Given this list of marker genes IGKV7-3, SLC14A2, KCNA6, NDUFA1, TMEM106A, SLC2A4, POLR1HASP, ERV3-1, HMGA2, NRF1, SMARCD1, LYST, COL14A1, MPP2, FANCC, ERCC4 (NCBI Gene Id 7509), CSPG4, IFNA21, FEV, SLC18A1, CHIC1, CCR9, SLC17A2, SLC30A3, PSG7, CSN3, ADCYAP1, PTPRU, CD8B, TAF1, here is a description of the gene set: species: Homo sapiens Neighborhood of ERCC4 Human Gene Set: GCM_ERCC4 Neighborhood of ERCC4 excision repair cross-complementing rodent repair deficiency, complementation group 4 in the GCM expression compendium